Given this list of marker genes NPR2, ENPP1, ABCC6, ESR1, NPR3, CTNS, CYP27B1, CCDC115, SLC34A3, VCP, DMP1, SLC34A1, CYP2R1, here is a description of the gene set: An abnormally increased level of bone isoforms of alkaline phosphatase, tissue-nonspecific isozyme in the blood. studied in species Homo sapiens Human Gene Set: HP_ELEVATED_ALKALINE_PHOSPHATASE_OF_BONE_ORIGIN Elevated alkaline phosphatase of bone origin